Given this list of marker genes STAT6, FOXP3, BCL2, SLAMF6, LGALS1, STAT3, CTSL, BRD4, THEMIS, IL6, PTPRC, BATF, JAK3, TOX, CD3D, CD3E, CD74 (NCBI Gene Id 972), TBX21, EP300, LY9, JAK1, SRF (serum response factor), BRD2, IL23A, ZFPM1, NFATC3, FOXN1, CD69, LOXL3, MTOR, IL6R, STK11, STAT5A, IL23R, CYLD, OPA1, IRF4, SPN (NCBI Gene Id 6693), SOCS3, ITPKB, CD3G (CD3 gamma subunit of T-cell receptor complex), ZAP70, BCL11B, IL6ST, PTPN2, BRAF, IL12B, DOCK2, SHH, IL12RB1, TNFSF18, here is a description of the gene set: Human Gene Set: GOBP_POSITIVE_T_CELL_SELECTION species: Homo sapiens The process of sparing immature T cells which react with self-MHC protein complexes with low affinity levels from apoptotic death.